Given this list of marker genes Cacnb2, Ryr2, Gjc1, Scn4b, Ank2, Cacna1c, Scn10a, Scn5a, Trpm4, Gjd3, Gja5, Cxadr, here is a description of the gene set: studied in species Mus musculus The process that mediates interactions between an AV node cell and its surroundings that contributes to the process of the AV node cell communicating with a bundle of His cell in cardiac conduction. Encompasses interactions such as signaling or attachment between one cell and another cell, between a cell and an extracellular matrix, or between a cell and any other aspect of its environment. Mouse Gene Set: GOBP_AV_NODE_CELL_TO_BUNDLE_OF_HIS_CELL_COMMUNICATION